Given this list of marker genes NOTCH2NLC, TSEN15, TANGO2, TSEN2, GIPC1, BMP4, PDGFRA, EXOSC9, ADCY6, SLC2A3, LRP12, NGLY1 (NCBI Gene Id 95041), ASPA, UBB, ATP1A2 (ATPase Na+/K+ transporting subunit alpha 2), SLC1A3, ARHGEF38, ARHGAP29, ADNP, SEPSECS, SCUBE3, TSEN34, TSEN54, CNTNAP1, RILPL1, CDH1, CACNA1A, YY1, GRIN1, RIC1, RAI1, MSX1, TP63, ZNF699, TAF1, HTT, DLX4, IRF6, ATP1A3, MTRFR, FLCN, COBLL1, DLG1, NECTIN1, GRHL3, here is a description of the gene set: Human Gene Set: HP_ORAL_PHARYNGEAL_DYSPHAGIA species: Homo sapiens Oral-pharyngeal dysphagia